The following is a description of a gene set: Cockayne syndrome (CS) is a human hereditary disease belonging to the group of segmental progerias, and the clinical phenotype is characterized by postnatal growth failure, neurological dysfunction, cachetic dwarfism, photosensitivity, sensorineural hearing loss, and retinal degradation. CS-B cells are defective in transcription-coupled DNA repair, base excision repair, transcription, and chromatin structural organization. Using array analysis, we have examined the expression profile in CS complementation group B (CS-B) fibroblasts after exposure to oxidative stress (H2O2) before and after complete complementation with the CSB gene. The following isogenic cell lines were compared: CS-B cells (CS-B null), CS-B cells complemented with wild-type CSB (CS-B wt), and a stably transformed cell line with a point mutation in the ATPase domain of CSB (CS-B ATPase mutant). In the wt rescued cells, we detected significant induction (two-fold) of genes out of the 6912 analysed. The patterns suggested an induction or upregulation of genes involved in several DNA metabolic processes including DNA repair, transcription, and signal transduction. In both CS-B mutant cell lines, we found a general deficiency in transcription after oxidative stress, suggesting that the CSB protein influenced the regulation of transcription of certain genes. Of the genes, 122 were differentially regulated by more than two-fold. Evidently, the ATPase function of CSB is biologically important as the deficiencies seen in the ATPase mutant cells are very similar to those observed in the CS-B-null cells. Some major defects are in the transcription of genes involved in DNA repair, signal transduction, and ribosomal functions. Human Gene Set: KYNG_RESPONSE_TO_H2O2_VIA_ERCC6 species: Homo sapiens from publication Kyng KJ, May A, Brosh RM Jr, Cheng WH, Chen C, Becker KG, Bohr VA (PMID 12606941) Genes down-regulated in CS-B cells (Cockayne syndrome fibroblast, CS) with defficient ERCC6 in response to hydrogen peroxide., and this is the list of marker genes: CDC34, RCC1, TRIM58, CRYAB, PLXNA1, UNG, CUX1, RPL21, CKMT2, RPL31, FLOT2, RPL7A, DNAJB1, OAZ2, CCND1, CTSS, TCF3